The following is a description of a gene set: species: Homo sapiens Human Gene Set: MIR499B_3P from publication Chen Y, Wang X (PMID 31504780) Genes predicted to be targets of miRBase v22 microRNA hsa-miR-499b-3p in miRDB v6.0 with MirTarget v4 prediction scores > 80 (high confidence targets)., and this is the list of marker genes: TTN, TSPYL1, KDM5B, ARL5A, STIM2, TCF7L2, AKAP6, SUGP2, DCAF8L1, TMEM132B, MBD2, GABRB3, CRISPLD1, IVNS1ABP, UBE2D3, KBTBD2, MSANTD2, SUCO, SNX3, EPGN, TAOK3, OMG, MAPK8IP3, SNAP25, SLC30A4, MAD2L1, DDX46, TMEM178B, CAPRIN2, RAP1GDS1, ZEB2, FOXN3, TMEFF1, MEOX2 (mesenchyme homeobox 2), NEK2, FIGN, CEP44, USP9X, CLDN22, SCRIB, KCNE4, ZNF529, IPO8, RNF144A, PDPK1, LSM8, GNG2, ZFAND5, MIER3, PRDM5, CACNA2D4, MAPK8, MAP4K3, SNCAIP, PI15, RUFY3, ANO5, PGAP1, JMJD1C, AAK1, C4orf46, SLC17A6, MSL2, RAP2B, CCNL1, MSANTD3-TMEFF1, EDEM3, PPP1R26, TAF9B, GPM6A, TENT4B, TET2, ZNF503, ZC3H6, TRDN, ERCC6, AGXT2, POM121C, ZNF99, MYO6, ADAMTS9, SDCBP, SLCO3A1, CDC42EP3, MFN2, TFCP2L1, HK2, MSI2, NAA15, HOMER1, ZNF257, RBM27, POM121, MAN2A1, SEC62 (NCBI Gene Id 7095), NDFIP1, MOCS2, PPP4R3A, ZNF585A, PAPOLB, ITFG1, PDZD8 (NCBI Gene Id 118987), FGFBP3, ZIC2, ODF2L, FZD9, SMOC2, LEPR, FOXN2, REEP3, PITPNA, SPIN1, USP3, EDIL3, MARK1, SEC24A, UBE2E3, PSMG4, MMUT, DLL1, OTUD6B, ATOSA, SEPTIN7, EYA1, NECTIN1, TRIO, EGR2, PRKG1, HACD4, BCLAF1, MAP3K1, HOXA5, TENM3, NRIP1, SOX6, UEVLD, SON, PCM1, TANC1, PAK3, PCDH11Y, FUT9, MAF, OTUD4, GXYLT1, LRP1B, TRAPPC11, LAMB3, PKP1, HEATR5A, STXBP5L, TBX3, BRD1, ERC2, PDGFC, MRTFB, XKR4, UBFD1, TRIB2, FRY, CXXC4, MBTPS2, TMX1, PLS3, GRAMD1C, ZNF260, DMXL2, PPM1B